The following is a description of a gene set: studied in species Mus musculus Mouse Gene Set: GOBP_ENDOTHELIAL_CELL_FATE_COMMITMENT The commitment of a cell to an endothelial cell fate and its capacity to differentiate into an endothelial cell., and this is the list of marker genes: Rbpj, Flvcr2 (feline leukemia virus subgroup C cellular receptor 2), Dll1, Nr2f2, Acvr1, Hoxa13, Pdpn, Prox1